Given this list of marker genes COL6A6, COL6A1, COL6A2, COL6A5, COL6A3, COL7A1, here is a description of the gene set: species: Homo sapiens The structure located at the interface of the basement membrane and interstitial extracellular matrix and anchoring the two types of ECM to one another. Human Gene Set: GOCC_BASEMENT_MEMBRANE_INTERSTITIAL_MATRIX_INTERFACE